The following is a description of a gene set: Defective B4GALT7 causes EDS, progeroid type studied in species Homo sapiens Human Gene Set: REACTOME_DEFECTIVE_B4GALT7_CAUSES_EDS_PROGEROID_TYPE, and this is the list of marker genes: SDC3, GPC5, CSPG5, GPC1, GPC2, CSPG4, GPC3, VCAN, BGN (NCBI Gene Id 633), B4GALT7, HSPG2, BCAN, SDC1, SDC2, AGRN, NCAN, SDC4, GPC6, GPC4, DCN